The following is a description of a gene set: from publication Chen Y, Wang X (PMID 31504780) Human Gene Set: MIR4451 studied in species Homo sapiens Genes predicted to be targets of miRBase v22 microRNA hsa-miR-4451 in miRDB v6.0 with MirTarget v4 prediction scores > 80 (high confidence targets)., and this is the list of marker genes: AGAP1, RNF180, YWHAG, TUBD1, INSR, ATP8B4, BEGAIN (brain enriched guanylate kinase associated), KRTAP4-2, RGS16, ELMOD2, SLMAP, LTBP1 (NCBI Gene Id 4052), SUDS3, UNC13C (unc-13 homolog C), LINGO2, JAK1, RAP1GDS1, ACP7, ARFGEF2, DYNAP, AFF2, CEP350, TFAP2D, KLHL23, SLC26A2, MOSPD2, UNC13D, HSPA5 (heat shock protein family A (Hsp70) member 5), CCL16, KLB, TMEM68 (NCBI Gene Id 137695), PPFIBP1, UGT2A2, CADPS2, AQP9, PARP1, TMEM38A, ALOX15B, CUL4B, ZNF134, SPATA19, REDIC1 (NCBI Gene Id 283461), SLC25A53, TYW5, KCNJ13, ZNF776, TXLNG (taxilin gamma), DCUN1D4, DISC1, DNAAF11, DCAF10, PLCB4, ITGAD, MYORG, ASPH, RBM14, ZNF235, ST8SIA1, ARID4A, GPX5, GRIP1, THOC2, TECTB, CTXN2, PSMB5, ATF7, DGKK, UGT2A1, GP6, C4orf46, WFDC5, SEMA4D, BCL3, PODNL1, STRIP2, SART1, SEM1, OLR1, TGFBRAP1, GIN1, LHFPL3, CSDE1, PDGFB, POC5, TMEM169, KCNB1, ELOC, BHMT2, IPP, MAP3K20, SPRY3, CDC14A, CDK12, VPS33B, DHDDS, NUCKS1, TMPRSS11F, CLASP2, YES1, A1CF, IL1RAP, PRR15L, PRDM14, EIF4G2, ELOVL2, PDPK1, NPHP3, GNL3L, GPALPP1, PEAK1, YBX1, SEC22B, TAF11, CRACD, RAPGEF2, COA1, F2RL3, OPALIN, KRTAP4-4, DENND6A, ZKSCAN4, PNMA8A, HPCAL4, EIF4EBP2, WNT2B (Wnt family member 2B), SLC25A36, CACNG8, CLDN1, DCSTAMP, CD40LG, HTR3B, PRUNE1, LPP, SEC16B, CSTA (cystatin A), SRGAP3, TKFC, CYB561D1, VPS26A, GDPD1, SFXN3, RNASE7, G6PC2, ATP8B1, BACH1, ROR1, RAB15, PRR11, APBB2, ARRDC5, MBNL3, GABRA4, CORIN (NCBI Gene Id 10699), TTC39A, LZTS3, CR1, AKAP5, HYCC2